Given this list of marker genes PLG, TFPI, PDGFA (NCBI Gene Id 5154), F2, F2R, F11, APOH, USF1, PLAT, PROCR, PROC, PDGFB, APOE, SERPINE1, PF4, ANO6, ADAMTS18, CPB2, PLAU, CD36, GP1BA, HRG, PDGFRA, CEACAM1, ADTRP, TMX1, FAP, PRKCD, F7, SERPINC1, PLAUR, THBS1, EMILIN2, PRDX2, CAV1, EMILIN1, KNG1 (NCBI Gene Id 589), PSEN1, TBXA2R, UBASH3B, ANGPT1, ANXA5, FGA, C1QTNF1, VTN, NOS3, FGG, KRT1, SERPINF2, CD9, HPSE, F12 (coagulation factor XII (Hageman factor)), MIR19B1, SERPINB2, ANGPT2, VKORC1, SERPINE2, F3, TSPAN8, KLKB1, SH2B3, ENPP4, PROS1, THBD, PRKG1, F2RL1, ST3GAL4, ANXA2, SERPING1, FOXA2, EPHB2, NFE2L2, HS3ST5, ALOX12, FGB, EDN1, here is a description of the gene set: Any process that modulates the frequency, rate or extent of coagulation, the process in which a fluid solution, or part of it, changes into a solid or semisolid mass. Human Gene Set: GOBP_REGULATION_OF_COAGULATION species: Homo sapiens